Given this list of marker genes Peg10, Gm18006, A430035B10Rik, Gm2651, Gm18222, Gm18421, Foxp2, Gm19272, Mir653, 1700016P04Rik, C1galt1, Thsd7a, Gm8820, Gng11 (NCBI Gene Id 66066), Gm20618, Rpa3, Ppp1r9a, Gm8428, Gm20619, Dlx6os1, Dlx6os2, Gm23013 (predicted gene, 23013), Mios, 1700012J15Rik, Gpr85, Pon2, Asb4, Gm8744, Sgce, Phf14, Gm32222, Gm20714, Rnps1-ps, Tmem106b, Ppp1r3a, Gm18289, Umad1, Gm24985, Gm8602, Pon1, Gmfg-ps, Gm2522, Gm8676, Vmn1r-ps6, Gm5873, Gm5300, Gm8652, Sem1, Bmt2, 1110019D14Rik, Col28a1, Sdhaf3, Gm15529, Vmn1r261, Calcr, Gm16042, Gm16055, 1700019G24Rik, Smim30, Gm8669, Gm26075, Gm2691, Mir489, Gm35822, Dync1i1, Col1a2, Ica1, Vps50, Ndufa4, 4930528H21Rik, Pon3, Gm23760, Slc25a13, Gm5110, Gm8686, Gm36406, Gm19252, Tmem168, Tac1, Gm44221, Vmn1r-ps5, Mdfic, Gm8579, Hepacam2, Vwde, Samd9l, Bet1, Casd1, Pdk4, Asns, Gm8649, Gngt1, Gm16123, Gm6578 (predicted gene 6578), Gm2796, Gm36503, Nxph1, Gm3148, Dlx6, Gm35736, Gm725, Gm20559, Tfpi2, Glcci1, Dlx5, AA545190, here is a description of the gene set: studied in species Mus musculus Mouse Gene Set: chr6A1